The following is a description of a gene set: species: Homo sapiens part of: Biosynthesis of specialized proresolving mediators (SPMs) Eicosapentaenoic acid (EPA), a major ω-3 polyunsaturated fatty acid (PUFA) found in fish oil is the source of E-series resolvins (RvEs), one of the specialized proresolving mediators (SPMs) that show potent anti-inflammatory and pro-resolving actions. The biosynthesis of RvEs occurs mainly during the process of inflammation when endothelial cells interact with leukocytes. EPA, circulating in plasma or released/mobilised from damaged cellular membranes on injury or infection, moves with edema into the tissue sites of acute inflammation where it is converted to exudate RvEs to interact with local immune cells. The initial transformation of EPA by aspirin-acetylated cyclooxygenase 2- and/or cytochrome P450-mediated catalysis can produce stereospecific resolvins (18(R)- or 18(S)-RvEs). Combinations of oxidation, reduction and hydrolysis reactions determine the type of resolvin formed (RvE1, RvE2 or RvE3). Reactome Pathway: Biosynthesis of EPA-derived SPMs, and this is the list of marker genes: ALOX15, HPGD, GPX4, PTGS2, ALOX5, LTA4H